The following is a description of a gene set: Bicarbonate transporters species: Mus musculus Mouse Gene Set: REACTOME_BICARBONATE_TRANSPORTERS, and this is the list of marker genes: Slc4a5 (solute carrier family 4, sodium bicarbonate cotransporter, member 5), Slc4a2, Slc4a3, Slc4a4, Slc4a8, Slc4a7, Slc4a10, Ahcyl2, Slc4a9, Slc4a1